Given this list of marker genes SOCS1, RASA1, IRS2, STAT5B (NCBI Gene Id 6777), MAPK3, STAT5A, SOS1, STAT3, PDK1 (NCBI Gene Id 5163), STAT1, GRB2, CISH, MAP2K1, JAK2, RAF1, PTPRU, SRC, SHC1, PIK3CG, IRS1, AKT1, PTPRC, EPOR (erythropoietin receptor), EPO, MAP2K2, MAPK1, here is a description of the gene set: species: Homo sapiens Human Gene Set: WP_EPO_RECEPTOR_SIGNALING EPO receptor signaling